Given this list of marker genes Exoc7, Exoc2, Slc30a8, Ins1, P4hb, Exoc1, Ins2, Slc30a5, here is a description of the gene set: Reactome Pathway: Insulin processing species: Mus musculus electronically inferred by orthology from the curated human pathway This event has been computationally inferred from an event that has been demonstrated in another species.<p>The inference is based on the homology mapping from PANTHER. Briefly, reactions for which all involved PhysicalEntities (in input, output and catalyst) have a mapped orthologue/paralogue (for complexes at least 75% of components must have a mapping) are inferred to the other species. part of: Peptide hormone metabolism